Given this list of marker genes BRK1, C18orf32, CSNK1A1, NUTF2, SCEL, IL18R1, MYH1 (NCBI Gene Id 4619), PSMD3, SYNGR1, BNIP3L, STX5, CORT, MTARC2 (NCBI Gene Id 96692), SLC35C2, TUBA1B, ARNT (NCBI Gene Id 405), RGS10, RPL28, RAB5IF, GCNT1, ABCB7, ATL2, MLH1, CD48 (NCBI Gene Id 962), MLPH, DLST, RRN3, PDRG1, SMIM14, ACSM2A, TACSTD2, SIPA1, CLIP2, DDX19A, ARL2, ERCC4, ADCY4, TRIR, NSUN2, NAA15, TNIP1, VTI1A, H3C7, FEM1B, ACOD1, SSBP4, FCGR2B, DCUN1D5, HNRNPC, VPS37B, C9orf72, KCNA7, OMP, ZNF740, CEBPD, SMPDL3A, HERPUD1 (homocysteine inducible ER protein with ubiquitin like domain 1), CDC26, NOC4L, SAA1, SDHC, PRKAB1, SLC39A6, GIPC1, ATP6AP2, CKAP4, SRPK2, GPCPD1, EZH1, PARK7, KDM5A, ALG5, ATP6V0B (ATPase H+ transporting V0 subunit b), BHLHE40, TEAD1, MBL2, PON3, SFMBT2, GSN, GABARAP, PSMB3, TRAF1, FYN, PREPL, GPSM3 (NCBI Gene Id 63940), NUSAP1, MYH2, CH25H, ZDHHC16, DNAAF10, RAB5B, SEC63, TSPAN32, GDPD3, CFAP20, TSPY1, THBS1, GADD45A, EIF3A, CMTM3, PLAUR, XDH, STIP1, ALDH9A1, FCER1G, CSNK2B, DAPK3, GRIA1, CSF2, PADI3, CD72 (NCBI Gene Id 971), GRIA4, USP14, ZFP64, SLMAP, MRPL35, TINF2, PRRG2, COQ3, CCL4, WWP2, ARPC1A, ELL2, ATP6V1G1, MRPL4, MOK, NAB1, IYD, GEM, TBPL1, NPNT, GTPBP2 (NCBI Gene Id 54676), HDHD2, SNAP23, VAV1, NDUFA2, RAB1A, SAYSD1, VDAC2, SLC22A18, TUBA3C, C15orf39, CCR2, RTF2, SSU72, PCBP2, ACY3, FHDC1, FAM20C, C5orf15, CTSC, ERF, TNF, DUSP16, ABHD8, TPI1, GAS6, GRN, DENND5A, HIPK3, NDUFS3, NDUFB2, PCBD2, PPM1A, VAMP3, NPY, MMP15, SFPQ, RMC1, AKAP7, HMGB2, PLD3, FYTTD1, NFS1, AP3S2, ABCD2, KIAA2013, TM2D2, EMC3, TANK, NAGK, PAFAH1B2, ATP2A3, MGST3 (microsomal glutathione S-transferase 3), HSPA1A, MSR1, CD81, HCCS, LGMN, FAM89B, BCL2A1, RAN, SERBP1, CCT3, CD300C, GMPPB, HNRNPU, DGAT1, TNFSF9, CYTH1 (cytohesin 1), here is a description of the gene set: Genes up-regulated in CD4 T helper cells Th0: 1h versus 10h. Human Gene Set: GSE43955_1H_VS_10H_ACT_CD4_TCELL_UP species: Homo sapiens Despite their enormous importance, the molecular circuits that control the differentiation of Th17 cells remain largely unknown. Recent studies have reconstructed regulatory networks in mammalian cells, but have focused on short-term responses and relied on perturbation approaches that cannot be applied to primary T cells. Here, we develop a systematic strategy – combining transcriptional profiling at high temporal resolution, novel computational algorithms, and innovative nanowire-based tools for performing gene perturbations in primary T cells – to derive and experimentally validate a temporal model of the dynamic regulatory network that controls Th17 differentiation. The network is arranged into two self-reinforcing and mutually antagonistic modules that either suppress or promote Th17 differentiation. The two modules contain 12 novel regulators with no previous implication in Th17 differentiation, which may be essential to maintain the appropriate balance of Th17 and other CD4+ T cell subsets. Overall, our study identifies and validates 39 regulatory factors that are embedded within a comprehensive temporal network and identifies novel drug targets and organizational principles for the differentiation of Th17 cells. from publication Yosef N, Shalek AK, Gaublomme JT, Jin H, Lee Y, Awasthi A, Wu C, Karwacz K, Xiao S, Jorgolli M, Gennert D, Satija R, Shakya A, Lu DY, Trombetta JJ, Pillai MR, Ratcliffe PJ, Coleman ML, Bix M, Tantin D, Park H, Kuchroo VK, Regev A (PMID 23467089)